The following is a description of a gene set: Mouse Gene Set: GOBP_THIAMINE_CONTAINING_COMPOUND_METABOLIC_PROCESS studied in species Mus musculus The chemical reactions and pathways involving thiamine (vitamin B1), and compounds derived from it., and this is the list of marker genes: Thtpa, Slc19a3, Slc19a2, Tpk1, Acp3, Slc25a19